Given this list of marker genes IL6, NFKB1, RELA, NFKBIA, IKBKB, MUC1, TNF, CHUK, IKBKG, here is a description of the gene set: species: Homo sapiens Altered glycosylation of MUC1 in tumor microenvironment Human Gene Set: WP_ALTERED_GLYCOSYLATION_OF_MUC1_IN_TUMOR_MICROENVIRONMENT